Given this list of marker genes CXCL1, CSF2, CXCL11, IL2RG, REG1A, MAP3K8, IRF1, A2M, IL17RB, IFNAR1 (NCBI Gene Id 3454), TLR2, IL3RA, JUN, SOCS1, IL2RA, DNTT, PIK3R5, LTBR, IL13RA1, CXCL3, SOCS3, TNF, PF4, MYD88, PTPN11, TNFRSF1A, PDGFC, ACVRL1, IL1B, IL15RA, OSMR, HMOX1, GRB2, HAX1, PIM1, ITGA4, IL12RB1 (NCBI Gene Id 3594), CCR1, STAT1, IL6, BAK1, CSF2RA, IFNGR2, PLA2G2A, CRLF2, IRF9, TYK2, CCL7, ITGB3, IL4R, ACVR1B, INHBE, CXCL10, CD38, CXCL9, TNFRSF12A, STAM2, IL1R2, IL10RB, TNFRSF21, IFNGR1, CNTFR, PTPN2 (NCBI Gene Id 5771), IL1R1, CXCL13, CD36, STAT2, PTPN1, TGFB1, LEPR, LTB (NCBI Gene Id 4050), STAT3, IL6ST, CD14, IL18R1, CSF2RB, CBL, TNFRSF1B, IL17RA, CD9, CSF3R, IL9R, FAS, IL7, EBI3, CSF1, CD44, here is a description of the gene set: studied in species Homo sapiens Genes up-regulated by IL6 via STAT3, e.g., during acute phase response. from publication Liberzon A, Birger C, Thorvaldsdóttir H, Ghandi M, Mesirov JP, Tamayo P (PMID 26771021) Human Gene Set: HALLMARK_IL6_JAK_STAT3_SIGNALING